Given this list of marker genes Pcsk9, Commd1, Scn1b, Camk2d, Nedd4, Scn3b, Nedd4l (NCBI Gene Id 83814), here is a description of the gene set: Mouse Gene Set: GOMF_SODIUM_CHANNEL_INHIBITOR_ACTIVITY Binds to and stops, prevents, or reduces the activity of a sodium channel. studied in species Mus musculus